The following is a description of a gene set: Human Gene Set: BRUECKNER_TARGETS_OF_MIRLET7A3_UP studied in species Homo sapiens Genes up-regulated in A549 cells (lung cancer) expressing MIRLET7A3 microRNA off a plasmid vector. MicroRNAs (miRNAs) are small noncoding RNAs that repress their target mRNAs by complementary base pairing and induction of the RNA interference pathway. It has been shown that miRNA expression can be regulated by DNA methylation and it has been suggested that altered miRNA gene methylation might contribute to human tumorigenesis. In this study, we show that the human let-7a-3 gene on chromosome 22q13.31 is associated with a CpG island. Let-7a-3 belongs to the archetypal let-7 miRNA gene family and was found to be methylated by the DNA methyltransferases DNMT1 and DNMT3B. The gene was heavily methylated in normal human tissues but hypomethylated in some lung adenocarcinomas. Let-7a-3 hypomethylation facilitated epigenetic reactivation of the gene and elevated expression of let-7a-3 in a human lung cancer cell line resulted in enhanced tumor phenotypes and oncogenic changes in transcription profiles. Our results thus identify let-7a-3 as an epigenetically regulated miRNA gene with oncogenic function and suggest that aberrant miRNA gene methylation might contribute to the human cancer epigenome. from publication Brueckner B, Stresemann C, Kuner R, Mund C, Musch T, Meister M, Sültmann H, Lyko F (PMID 17308078), and this is the list of marker genes: CTH, THSD4, DAPK1, PLA2G4A, KRAS, EHBP1, SULT2B1, FGL1, USP32, FGG, CYP24A1, KRT85, NFE2L2, FERMT1 (FERM domain containing kindlin 1), KRT9, RAB3D, OS9, AKAP12, SAT1, FGB, SLC12A2, TBC1D31, C7orf50, PTS (6-pyruvoyltetrahydropterin synthase), CYSTM1, POLB, LRP11, SMOC1, ACOX2, EFNA1, CYP1B1, ERRFI1, NOTCH3, RBM24, CXADR, XBP1, THSD7A, PERP, RHOV, RGCC, PITPNC1, GJA1, CD55, TBC1D15, PON2, PHACTR2, CHGB, COL4A4, CPEB4, LAMB3, MFSD12, DUSP5, PGD, ETNK1, DKK1, BCHE, ARHGAP26, VCAN, PCNA, ANXA11, IPO7, GFOD1, ATP1B3, ELF3, B4GALT5, LDHAL6A, PIR, CLDND2, EVA1C, ABLIM1, SEC11C, TMEM230, TESC, COX7C (NCBI Gene Id 1350), SLC23A2, PRDX1, SLC38A2, SH3BP5, FAT1, KLF4, USP9X, BTG1, GLIS3, GLRX, PPTC7, OSGIN2, FOXC1, FAM107B, WWC1, SDHA, KMO, LYST, FOXA1, LRATD2, MAGEA2, PTPN12, VDAC2, CDK6, REG3G, NDRG1, LGR4, GLMN, SAMD8, MAGEA6, TFPI, TXNRD1, ETV4, ACYP1, GABARAPL1, ADCK2